Given this list of marker genes ADGRB3, GPR88, C1QL1, EN1, TACO1, GIT1, DKK1 (NCBI Gene Id 22943), here is a description of the gene set: Any process in which an organism acquires a novel neuromuscular action or movement as the result of experience. Human Gene Set: GOBP_MOTOR_LEARNING studied in species Homo sapiens